Given this list of marker genes Rbp3 (NCBI Gene Id 218905), Opn1sw, Awat2, Dhrs3, Rlbp1, Opn1mw, here is a description of the gene set: The retinoid cycle in cones (daylight vision) species: Mus musculus Mouse Gene Set: REACTOME_THE_RETINOID_CYCLE_IN_CONES_DAYLIGHT_VISION